The following is a description of a gene set: Reactome Pathway: Coagulation pathway part of: Hemostasis This model describes the intricate interactions between various coagulation factors that, under normal physiologic conditions, occur on membrane surfaces of activated cells at the site of vessel injury. The cell-based model consists of several overlapping stages:<li>Initiation phase, which proceeds through the formation of the activated tissue factor (TF): factor VIIa (FVIIa) complex and TF:FVIIa-mediated generation of a small amount of thrombin (FII) on the membrane surfaces of TF-bearing cells (e.g., fibroblasts, pericytes).</li><li>Amplification phase, which is mediated by the small amount of thrombin produced in the TF-mediated initiation phase. On the platelet surface, thrombin activates factor XI (FXI), factor VIII (FVIII) and factor V (FV). The activated FXI (FXIa) converts factor IX (FIX) to FIXa, which binds the co-factor FVIIIa. The FIXa:FVIIIa complex (the tenase complex) generates activated factor X (FXa) (activated FX) which in turn binds FVa to form the FXa:FVa (prothrombinase) complex. The FXa:FVa complex converts prothrombin (FII) to thrombin (FIIa), which activates more FXI, FVIII and FV creating a positive feedback cycle. Additionally, interactions of FIIa with platelet surface receptors such as surface protease-activated receptors (PARs) contribute to the platelet's activation and degranulation, and the recruitment of additional platelets to the site of injury, where activated platelets aggregate to form the platelet plug (Swieringa F et al., 2018; Sang Y et al., 2021). Activated procoagulant platelets also release clotting factors and expose phosphatidylserine (PS) on their cell membranes providing a surface for the assembly of the tenase and prothrombinase complexes (Swieringa F et al., 2018; Sang Y et al., 2021).</li><li>Propagation phase, which occurs on the activated platelet surface, generates large amounts of thrombin via FXa:FVa-catalyzed cleavage of prothrombin.</li><li>In the final phase of clotting, thrombin produced through amplification and propagation stages converts soluble fibrinogen into fibrin, which polymerizes to form insoluble fibrin fibers that are crosslinked by thrombin-activated factor XIII (FXIIIa) to stabilize the platelet plug.</li><p>Each of these coagulation stages is tightly controlled by endogenous regulators to prevent excessive clotting that may lead to a pathologic thrombus formation. In this module we describe several natural anticoagulants including tissue factor pathway inhibitor (TFPI), protein C, protein S, thrombomodulin (TM) and antithrombin III. TFPI can form a quaternary complex with FXa, FVIIa and TF, effectively inactivating these clotting factors to restrict coagulation (Mast AE 2015; Mehic D et al., 2021). Protein C is activated by the thrombin:thrombomodulin complex on intact endothelial cells and along with cofactor protein S, inhibits coagulation process by deactivating FVa and FVIIIa. Heparan sulfate-bound antithrombin III (SERPINC1) forms a complex with thrombin and other clotting factors such as FXa and FXIa to prevent clot formation (Zhang W et al., 2005; reviewed by Rezaie AR et al., 2020). species: Homo sapiens, and this is the list of marker genes: SERPINE2, GPC4, F7, F10, PRTN3, F13A1, ANO6 (NCBI Gene Id 196527), SERPINE1, SERPINA5, GP1BB, PROZ, GP1BA, SDC4, ITGA2B, GPC1, KLKB1, GPC2, GP5, SMPD1, F13B, PROS1, F8, HSPG2, APP, VWF, FGB, ANO5, F5, GPC6, F11, F3 (coagulation factor III), PROC, GPC5, TFPI, PROCR, F2, PF4, FGG, GPC3, KNG1, SDC3, F9, SERPINC1, SDC1, SERPING1, GP9, FGA (fibrinogen alpha chain), F12, THBD (NCBI Gene Id 7056), ADAMTS13, AGRN, PF4V1, F2R, SERPINA10, SERPIND1, ITGB3, SDC2, CD177